Given this list of marker genes SCN5A, SCN2B, KCNJ2, LMOD2, SCN3B, GJA5, CAP2, PSEN1, SDHA, BAG3, ACTN2, PLN, GATA4, GATAD1, MYBPC3, MYH7, VCL, GET3, KCNE2, HAND2, TAFAZZIN, TCAP, MYH6, CSRP3, TNNI3, TXNRD2, ANKRD1, NUP155, FHL2, DES, TNNT2, NKX2-5, SCN1B, RBM20, ACTC1, MTHFR, MYPN, KCNJ5, TNNC1, KCNA5, RAF1, TTN, KCNQ1 (potassium voltage-gated channel subfamily Q member 1), ABCC9, GATA6, LDB3, VEZF1, RPL3L, JPH2, NKX2-6, NEXN, CRYAB, PITX2, DOLK, KCNE1 (potassium voltage-gated channel subfamily E regulatory subunit 1), TPM1, LAMA4, DSP, MYL4, SGCD, DSG2, NPPA, GATA5, TMPO, KCNJ3, ADA2, TAF1A, PSEN2 (presenilin 2), SCN4B, LMNA, BAG5, PRDM16, FKTN, DMD, PPCS, here is a description of the gene set: A cerebrovascular accident (stroke) that occurs because of thromboembolism. species: Homo sapiens Human Gene Set: HP_THROMBOEMBOLIC_STROKE Thromboembolic stroke